Given this list of marker genes Apoa1, Lypla1, Zdhhc14, Zdhhc18, Zdhhc3, Zdhhc9, Apoa5, Atg10, Zdhhc2, Apom, Atm, Porcn (porcupine O-acyltransferase), Ppm1b, Notum, Golga7, Zdhhc15, Zdhhc8, Rab3gap1, Irgm2, Mboat4, Ulk1, Lypla2, Ppt1, Apob, Apoe, Gba1, Zdhhc17, Npc1l1, Glul, Apod, Rabl3, Pcsk9, Nmt1, Angptl8, Irgm1, Selenok, Abhd13, Pik3c3, Lipg, Dgat2, Zdhhc11, Hhat, Zdhhc12, Zdhhc7, Zdhhc21, Zdhhc1 (NCBI Gene Id 70796), Atg7, Zdhhc20, Apoa4, Lcat (lecithin cholesterol acyltransferase), Zdhhc22 (NCBI Gene Id 632803), Zdhhc23, Abca1, Abhd17b, Zdhhc6 (zinc finger, DHHC domain containing 6), Abhd17a, Apoa2, Itgav, Zdhhc16, Abhd10, Map6d1, Ldlr, Zdhhc19, Hhatl, Ugcg, Apoc1, Dbi, Col6a1, Alox12b, Itgb3, Ppara, Lyplal1, Mttp, Abhd17c, Atg13, Apoc3, Ctsd, Atg5, Rb1cc1, Pemt, Apoc2, Nmt2, Lep, Wipi2, Igtp, Atg101, Abhd12, Svip, Samd1, Rab3gap2, Ppm1a, Clip3, Apobec1, Zdhhc5, Olr1 (oxidized low density lipoprotein (lectin-like) receptor 1), Lipa, Atg16l1, here is a description of the gene set: species: Mus musculus Mouse Gene Set: GOBP_LIPOPROTEIN_METABOLIC_PROCESS The chemical reactions and pathways involving any conjugated, water-soluble protein in which the covalently attached nonprotein group consists of a lipid or lipids.